The following is a description of a gene set: Reactome Pathway: PIP3 activates AKT signaling Signaling by AKT is one of the key outcomes of receptor tyrosine kinase (RTK) activation. AKT is activated by the cellular second messenger PIP3, a phospholipid that is generated by PI3K. In ustimulated cells, PI3K class IA enzymes reside in the cytosol as inactive heterodimers composed of p85 regulatory subunit and p110 catalytic subunit. In this complex, p85 stabilizes p110 while inhibiting its catalytic activity. Upon binding of extracellular ligands to RTKs, receptors dimerize and undergo autophosphorylation. The regulatory subunit of PI3K, p85, is recruited to phosphorylated cytosolic RTK domains either directly or indirectly, through adaptor proteins, leading to a conformational change in the PI3K IA heterodimer that relieves inhibition of the p110 catalytic subunit. Activated PI3K IA phosphorylates PIP2, converting it to PIP3; this reaction is negatively regulated by PTEN phosphatase. PIP3 recruits AKT to the plasma membrane, allowing TORC2 to phosphorylate a conserved serine residue of AKT. Phosphorylation of this serine induces a conformation change in AKT, exposing a conserved threonine residue that is then phosphorylated by PDPK1 (PDK1). Phosphorylation of both the threonine and the serine residue is required to fully activate AKT. The active AKT then dissociates from PIP3 and phosphorylates a number of cytosolic and nuclear proteins that play important roles in cell survival and metabolism. For a recent review of AKT signaling, please refer to Manning and Cantley, 2007. studied in species Homo sapiens part of: Intracellular signaling by second messengers, and this is the list of marker genes: MIR26A1, PSMB2, MIR20A, RICTOR, NRG1, TNKS, PSMB7, EGFR, PSMC1, PHC1, PIP4K2C, FGFR4, PIK3R2, RNF2, PPP2R5D, FGFR1, KITLG, THEM4, BAD, PSMA7, PSMB4, NTRK3, CBX8, MIR19A, FGF19, PSMA2, FGF20, AREG, RING1, TNRC6C, EPGN, MYD88, MIR93, INS (insulin), PPP2R5E, EGR1, FOXO3, FGF10, FGF23, CD80, PIK3CG, SEM1, PHLPP1, PTENP1, PDGFRB, FGF3, HDAC2, AKT1S1, FOXO6, PHC2, MTA2, CD28, AKT1, JUN, MIR25, LAMTOR5, MKRN1, PIP5K1A, FGF16, PSMA1, PIK3CD, PSMA5, HDAC5, IRAK4, PIP4K2B, CBX4 (NCBI Gene Id 8535), MAPK1, NR2E1, FLT3, RCOR1, SGK1, PPP2CB, HDAC3, PREX2, CDKN1B, PSMD2, MIR26A2, NEDD4, OTUD3, CSNK2B, KLB, CD86, AKT3, XIAP, PDGFA, PSMB1, EED, RBBP7, TRAT1 (NCBI Gene Id 51488), HGF, PIK3R1, USP7, MIR214, TGFA, RNF146, FGF7, MTOR, FGF2, PPARG, TNRC6B, PPP2CA, LCK, GATAD2A, CDKN1A, FGF6, NTF4, CHD4, PDPK1, AGO2 (argonaute RISC catalytic component 2), PTPN11, PSMD1, IL1RL1, MIR17, PSMD12, BTC, CREB1, STUB1, SNAI1, FGF5, MIR106A (NCBI Gene Id 406899), ERBB4, FOXO1, PIK3CB, PSMA4, STRN, PSMC5, FGF22, SLC38A9, RHEB, M, KDM1A, PSMD13, GATAD2B, PPP2R5B, AKT2, SCMH1, CASP9 (caspase 9), LAMTOR1, UBC, IER3, PIK3R3, MAPK3 (mitogen-activated protein kinase 3), GSK3B, EZH2, TSC2, TNRC6A, MLST8, ATN1, RPTOR, RHOG, FGF8, TRAF6, ICOS, MTA1 (metastasis associated 1), FGF17, ESR1, MIR205, PSMB5, TNKS2, ADRM1, PIP5K1C, FRS2, NRG2, SRC, ATF2, PSMC4, ERBB3, IRS2, FLT3LG, PPP2R5C, EREG, USP13, MAF1, AGO3, RRAGD, INSR, VAPA, N, BDNF, FOXO4, FGF4, ESR2 (estrogen receptor 2), CD19, MOV10 (NCBI Gene Id 57723), UBA52, SALL4, PSMD11, NR4A1, RBBP4, KL, MIR19B1, PSMA6, LAMTOR3, PSMD7, PDGFB, HDAC7, RAC2, RPS27A, FGF1, AGO4, FYN, WWP2, FGFR3, MDM2, PIK3R6, VAV1 (NCBI Gene Id 7409), PDGFRA, ERBB2, MECOM, NRG4, TP53, KIT, REST, PSMD14, PPP2R1B, CNOT6L, PSMC6, LAMTOR4, GAB2, PIP5K1B, NTF3 (NCBI Gene Id 4908), CSNK2A1, LAMTOR2, MIR106B, HBEGF, MET, TRIM27 (tripartite motif containing 27), AGO1, RRAGB, MBD3 (methyl-CpG binding domain protein 3), PSMC2, PSMA3, MIR19B2, UBB, FGFR2, PSMD6, MIR22, PSMD3, RAC1, GSK3A, PIK3AP1, PSMB3, RPS6KB2, FRK, CBX6, EGF, NRG3, MAPKAP1, FGF18, PTEN, PHC3, IL33, MIR20B, CHUK, IRAK1, CHD3, CBX2, CSNK2A2, PML, GAB1, MIR21, PPP2R5A, SUZ12, HDAC1, PHLPP2, BMI1, PRR5, RRAGA, MTA3, PIK3R5, RRAGC, SNAI2, IRS1, NTRK2, PSMB6, IL1RAP, FGF9, PPP2R1A, PIK3CA, PIP4K2A, TRIB3 (tribbles pseudokinase 3), GRB2, PSMD8, PSMC3